Given this list of marker genes MKS1 (MKS transition zone complex subunit 1), PLAG1, CD28, LDB2, URB1, ITSN1, RNASEH2B, PLXDC1, ANGEL1, IL6ST, OR2A20P, PTPRK, LPIN2, CYLD, LZTFL1, CHI3L2, SMC4, TXNRD3, SND1, CORO1B, PPP1R17, MCUB, COL5A2, MAP7D3, SUPT3H, MTCL1, RPP40, HPGD, ADAM23, SMIM8, RPSAP44, PMAIP1 (phorbol-12-myristate-13-acetate-induced protein 1, NCBI Gene Id 9305), TSC22D3, SEPTIN7, ATF7IP2, URB2, ROBO1, JPT2, HNRNPA1P37, DIXDC1, DNAJA3, ID3 (NCBI Gene Id 3399), SOX4, RNF144A, EDAR (NCBI Gene Id 1898), ITM2A, BCL11A, PFKM, BTG1, COX6CP1, UBAP2L, PIK3C2B, LEPROTL1, MTF2, IGF2BP3, TTN, TRBV21-1, PKIA (cAMP-dependent protein kinase inhibitor alpha), SLC25A5, ELOA-AS1, KPNB1, DLEU1 (NCBI Gene Id 647154), EEIG1, COX11, APTX, TTC28, SLC16A10, CD40LG, DMAC2L (distal membrane arm assembly component 2 like), CD69, MARCHF3, PRIM1, MLLT11, PLSCR3, RPS23, KLF2, JUN, DCHS1, TMEM161A, ADA, RHOH, TNIK, APOO, ETS1, BZW2, LRRN3, RPL13A, RLN2, MAGED1 (NCBI Gene Id 9500), AGMAT, NREP, TENM1, ULK2, CEP83, TRIM66, EXTL2, SUSD4, LRRC1, RPS6KA5, SLC6A2, RPLP0, PIN4, POLR1HASP, PRRC1, DIPK1A, RETREG1, CATSPER2, ATP6V1G2, CR2, PTCD2, NPAS2, KLHL3, TSPYL5, VPS13A, TUBB, ATXN10, SRR, SEMA4F (NCBI Gene Id 9408), SYNJ2, NPM3, TOB1, CYP4A11, MAPKBP1, OR1A2, WDR77, STOML1, RAD1, AUTS2, RPL22, RHOBTB3, NMT2, NUDT13, APOC1, CYB5A, MLLT3, RAB25, CAMSAP2, LIMS2, GAL3ST4, NCOA3, ADGRL1, CCDC28B, IL7R, ADD3, DHRS3 (dehydrogenase/reductase 3), PITX1-AS1, SEPTIN9, MAPRE2, PCDH9 (NCBI Gene Id 57123), ENPP2, PUM1, MAN1C1, RPSAP20, DDX17, SCN3A, CDC14A, here is a description of the gene set: Each infectious agent represents a unique combination of pathogen-associated molecular patterns that interact with specific pattern-recognition receptors expressed on immune cells. Therefore, we surmised that the blood immune cells of individuals with different infections might bear discriminative transcriptional signatures. Gene expression profiles were obtained for 131 peripheral blood samples from pediatric patients with acute infections caused by influenza A virus, Gram-negative (Escherichia coli) or Gram-positive (Staphylococcus aureus and Streptococcus pneumoniae) bacteria. Thirty-five genes were identified that best discriminate patients with influenza A virus infection from patients with either E coli or S pneumoniae infection. These genes classified with 95% accuracy (35 of 37 samples) an independent set of patients with either influenza A, E coli, or S pneumoniae infection. A different signature discriminated patients with E coli versus S aureus infections with 85% accuracy (34 of 40). Furthermore, distinctive gene expression patterns were observed in patients presenting with respiratory infections of different etiologies. Thus, microarray analyses of patient peripheral blood leukocytes might assist in the differential diagnosis of infectious diseases. Human Gene Set: GSE6269_E_COLI_VS_STAPH_AUREUS_INF_PBMC_UP species: Homo sapiens from publication Ramilo O, Allman W, Chung W, Mejias A, Ardura M, Glaser C, Wittkowski KM, Piqueras B, Banchereau J, Palucka AK, Chaussabel D (PMID 17105821) Genes up-regulated in comparison of peripheral blood mononuclear cells (PBMC) from patients with acute E. coli infection versus PBMC from patients with acute S. aureus infection.